Given this list of marker genes Slc1a5, Slc1a4, Slc38a2, Slc38a5, Sfxn1, Sfxn3, here is a description of the gene set: studied in species Mus musculus The directed movement of L-serine, the L-enantiomer of 2-amino-3-hydroxypropanoic acid, into, out of or within a cell, or between cells, by means of some agent such as a transporter or pore. Mouse Gene Set: GOBP_L_SERINE_TRANSPORT